Given this list of marker genes ZCCHC7, MTREX, RBM7, ZCCHC8, EXOSC10, here is a description of the gene set: The chemical reactions and pathways resulting in the breakdown of snRNA, small nuclear RNA, low-molecular-mass RNA molecules found in the eukaryotic nucleus as components of the small nuclear ribonucleoprotein. Human Gene Set: GOBP_SNRNA_CATABOLIC_PROCESS studied in species Homo sapiens